Given this list of marker genes SREBF1, PPARD, PNPT1, VEGFA, GATA2, MYOCD, FOSL1, MRTFA, NFIB (nuclear factor I B), TEAD1, ZNF512B, FOXO3, MRTFB, RELA, POU2F1, SMARCA4, RARA, REST, DDX5, IL10, IL6, HOTTIP, BMP4, SMAD1, APP, QKI, MYB, FOXA1, TERT, HRAS, NR3C1, PDGFB, PPARA, PRL, RC3H1, FOS, RC3H2, HIF1A, SMAD3, STAT3, ESR1, TP53, ETS1, NFATC3, GATA3, SOX9, PPARG, BMPR1A, APLN, NEAT1, AGT, NOTCH3, NOTCH2, NR1H2, KLF4, TNF, SMAD6, WT1, ATOH8, NCOR2, YY1, ZC3H12A, POU5F1, SREBF2, BMP2, DNM3OS, SPI1, TWIST1, LIN28B, TGFB2 (NCBI Gene Id 7042), EGFR, NGFR, MYC, GNL3, SMAD4, TGFB1, DROSHA, NFKB1, NCOR1, TENT2, PAX6, SRF (serum response factor), FGF2, XIST, JUN, NFATC4, MYCN, EGR1, MALAT1, AR, ZSWIM8, LILRB4, here is a description of the gene set: species: Homo sapiens Any process that modulates the frequency, rate or extent of miRNA metabolic process. Human Gene Set: GOBP_REGULATION_OF_MIRNA_METABOLIC_PROCESS